Given this list of marker genes TNNC1, PAH, RET, LTBP2, DSG2, ANXA5, CDH3, PLS3, MID1, THBS4, MMP2, ANXA1, DSG3, SCO2, MMP13, RCVRN, RYR3, ENPEP, ADPRH, GAS6, GSN, ALOX5, SCG2, C1S, ANXA4, CDH17, TP53I3, CA12, S100A4, ADGRE1, ADAM9, TF (NCBI Gene Id 7018), MMP10, LRP1, CDH6, PAM, S100A13, LDLR, ITGAL, ANPEP, CALB2, ADH1C, FAT1, ADH4, NELL1, PFKP, EFEMP2, MMP7, RGN, MRC1, MT3, UMOD, CDH13, EFEMP1, SPARC, PLSCR1, C1R, MMP14, CDH5, SPOCK2, ADH7, MMP12, MMP3, PPA1, PLCG2, FCN1, CP, FBLN1, CALML3, PROC, S100A11, MST1, MMP9, MYL12A, CRB1, ACSL3 (NCBI Gene Id 55484), COMP, ITGAX, LOXL1, ARG1, CAPN2, S100A3, CHGA, PRF1, S100A7, PLA2G10, MMP1, AOC1, SLIT3 (NCBI Gene Id 6586), ALOX15B, S100A2, BMP1, FBN2, ANXA3, DGKA, AIF1, TNFAIP3, ANXA8L1 (NCBI Gene Id 96395), LTF, FSTL1, ANXA2, MT1H, S100P (S100 calcium binding protein P), CA2, DSG1, MT1G, MT1L (metallothionein 1L (pseudogene)), ACSL1, CALU, S100A9, SLIT2, LTBP1, THBS2, FBLN2, CA4, CDH1, TNNC2, LAP3, ADH1A, ALPI, F13A1 (NCBI Gene Id 2162), CA11, CDH2, SPARCL1, F10, MGP, ITGA2, FASN, FBN1, ITGAM, THBD, PLA2G2A, S100A10, here is a description of the gene set: Metal / Ca ion binding. Human Gene Set: MODULE_324 species: Homo sapiens